Given this list of marker genes GRHL2, MSX2, TMEM231, WDPCP, TRAF3IP1, SALL1, INTU, OSR1, IFT52, NOG, MAP3K20, LRP5, LMBR1, HDAC1, CHST11, MEGF8, HOXD13, TBX3, ECE1, BMP4, HOXA11, MKS1 (NCBI Gene Id 54903), HAND2 (NCBI Gene Id 9464), HOXD12 (homeobox D12), B9D1, WNT7A, LNPK, TTBK2, TBC1D32, TWIST1, TBX2, GNA12, IHH, TULP3, MSX1, SHH, PRICKLE1, NOTCH1, MYCN, FZD6, CTNNB1, FREM2, ALX4, FLVCR1 (NCBI Gene Id 559), C2CD3, LRP4, BMPR1A, WNT5A, HDAC2, BCL2L11, OSR2, BPNT2, TMEM107, GLI3, SMAD4, ZBTB16, CREBBP, IFT140, BAX, SFRP2, HOXC11, here is a description of the gene set: studied in species Homo sapiens The process, occurring in the embryo, by which the anatomical structures of the digit are generated and organized. A digit is one of the terminal divisions of an appendage, such as a finger or toe. Human Gene Set: GOBP_EMBRYONIC_DIGIT_MORPHOGENESIS